The following is a description of a gene set: studied in species Homo sapiens Human Gene Set: HP_STENOSIS_OF_THE_EXTERNAL_AUDITORY_CANAL Stenosis of the external auditory canal An abnormal narrowing of the external auditory canal., and this is the list of marker genes: SIX5, SIX1, PORCN, FGFR2, MAF, WBP4, SLC26A2, GPRASP2, CTBP1, PLCB4, B3GLCT, FGFRL1, TBX15, RPS28 (NCBI Gene Id 6234), EDNRA, MAFB, NSD2, CPLX1, SOST, MED12, LETM1, ANAPC7, FAT4, EYA1, SF3B4, HOXA2 (NCBI Gene Id 3199), SALL4, CHN1, COG1, COL7A1, SLC12A2, EDN1, TP63, POR, GMNN, COL2A1, SP7, RPL26, HMX1, GNAI3, TWIST2